The following is a description of a gene set: Mouse Gene Set: GOMF_PROTEIN_PHOSPHATASE_1_BINDING Binding to a protein phosphatase 1. studied in species Mus musculus, and this is the list of marker genes: Ppp1ca, Fer, Pirb, Ppp1r3d, Ppp1r15a (protein phosphatase 1, regulatory subunit 15A), Dynlt4 (dynein light chain Tctex-type 4), Ppp1r11, Tmem225, Ppp1r3f, Pawr, Tprn, Cdc5lrt6, Cdc5lrt10, Ppp1r3a, Cdc5lrt7, Ppp1cc, Stau1, Ppp1r3b, Cdc5lrt8, Phactr1, Lmna, Cdc5l, Shoc2, Cdc5lrt4, Ppp1r10, Phactr4, Ppp1r3c, Adissp, Cdc5lrt9, Cdc5lrt1, Ppp1r9b, Akap11, Sh3rf2, Kcnq1, Smtnl1, Ppp1r3g, Ppp1r9a, Ppp1r3e (protein phosphatase 1, regulatory subunit 3E), Cdc5lrt5